The following is a description of a gene set: studied in species Mus musculus A class of nuclear body, first seen after silver staining by Ramon y Cajal in 1903, enriched in small nuclear ribonucleoproteins, and certain general RNA polymerase II transcription factors; ultrastructurally, they appear as a tangle of coiled, electron-dense threads roughly 0.5 micrometers in diameter; involved in aspects of snRNP biogenesis; the protein coilin serves as a marker for Cajal bodies. Some argue that Cajal bodies are the sites for preassembly of transcriptosomes, unitary particles involved in transcription and processing of RNA. Mouse Gene Set: GOCC_CAJAL_BODY, and this is the list of marker genes: Nhp2, Prpf4, Smndc1, Eaf1, Hmbox1, Nop10, Npat, Srrm2, Cdk2, Prpf31, Wrap53, Angel2, Ush1g, Rdm1, Garin3, Ddx46, Phax, Fmr1, Fbl, Gemin4, Dkc1, Zpr1, Gar1, Xpo1, Zc3h8, Prpf3, Vrk1, Uspl1, Coil, Ewsr1, Hnrnpa2b1, Lsg1, Toe1, Ell, Eftud2, Sart3, Fam118b, Arih1, Oip5, Habp4, Ak6, Lsm10, Nop58, Ice1, Smn1, Isg20, Frg1, Hspb7, Nolc1, Fbll1, Sart1 (NCBI Gene Id 20227), Ice2, Snrpc, Tgs1 (trimethylguanosine synthase 1), Hinfp, Zfp473